The following is a description of a gene set: studied in species Homo sapiens Human Gene Set: GOMF_S_ADENOSYLMETHIONINE_DEPENDENT_METHYLTRANSFERASE_ACTIVITY Catalysis of the transfer of a methyl group from S-adenosyl-L-methionine to a substrate., and this is the list of marker genes: SETMAR, PRMT9, TMT1B, KMT2B, METTL6 (NCBI Gene Id 131965), PRDM8, TRMO, PRDM7 (PR/SET domain 7), SETD1B, SETD1A, PRDM6, KMT5A, SETBP1, FTSJ1, METTL4, NSD3, PRMT5, ASH1L, NTMT1, METTL14, MRM3, PCIF1, EZH2, TRDMT1, SETD7, NSUN2, ICMT, METTL15P1, SETD9, TGS1, COMT, ASMT, SETD5, TFB2M, METTL22, EEF1AKMT2, METTL8, WDR5, TRMT1, NSUN5P1, NDUFAF7, KMT2D, NSUN4 (NOP2/Sun RNA methyltransferase 4), MECOM, DIMT1, MRM1, PRMT2, CMTR1, METTL21C, TPMT, TRMT10B, SMYD1, TRMT5, ETFBKMT, GNMT (NCBI Gene Id 27232), NNMT, FDXACB1, AS3MT, PCMT1, FBXO11, METTL13, HEMK1, METTL25B, TMT1A, METTL15, SPOUT1, PRDM2, ANTKMT, PRMT1, NSD2, METTL1, KMT5C, TTLL12, NSUN5, EMG1, EEF1AKMT1, CSKMT, TRMT10C, EEF1AKMT3, TRMT2B, N6AMT1, TARBP1, TRMT9B, DNMT1, TRMT61A (NCBI Gene Id 414769), METTL3, KMT5B, DNMT3A, SETD4, METTL2B, PRDM9, NSUN3, FBLL1, THUMPD3, EEF2KMT, COMTD1, SUV39H1, SETD6, PCMTD2, ARMT1, COQ3, MEPCE, LCMT1, TFB1M, CAMKMT, EZH1, FTSJ3, ATPSCKMT, SMYD3, EEF1AKMT4, HNMT, CARNMT1, NSD1, INMT, CMTR2, METTL9, NDUFAF5, FAM86B2, PRDM16, CARM1, FBL, TRMT61B, SETDB2, NOP2, TRMT11, KMT2A, NTMT2 (N-terminal Xaa-Pro-Lys N-methyltransferase 2), EHMT2, SMYD2, SETD3, PRMT3, TRMT2A, METTL23, BUD23, GAMT, ALKBH8, PCMTD1, NSUN6, MRM2, DOT1L, TRMT10A, METTL16, METTL18, RNMT, METTL21A, PEMT, PRMT7, SETD2, NSUN5P2, TRMT1L, PNMT, PRMT6, DPH5, VCPKMT, JARID2, FAM86B1, EHMT1, METTL2A, SETDB1, THUMPD2, SUV39H2, METTL5, PRMT8, ZCCHC4, KMT2C, SMYD5, DNMT3B